The following is a description of a gene set: studied in species Homo sapiens Binding to a keratin filament, an intermediate filament composed of acidic and basic keratins (types I and II), typically expressed in epithelial cells. Human Gene Set: GOMF_KERATIN_FILAMENT_BINDING, and this is the list of marker genes: SIRT1, KRT74, VIM, FAM83H (NCBI Gene Id 286077), KRT14, EPPK1